Given this list of marker genes Dcaf7, Syt4, Itgb3, Dapp1, Klf12, Erbin, Rhbdl3, Arhgap32, Gas7, Tyk2, Camta1, Igf2r, Acp2, Map2k4, H2-D1, Spcs3, Elovl1, Mex3c, Ctns, Crygs, Cdk18, Tpm3, Bsn, Slc45a4, Ralgapa2, Klhl28, Heyl, Lrrc74b, Creb3l2, Fbrs, Pkia (protein kinase inhibitor, alpha), Strada, Pag1, Acad8, Cacna1d, Tanc2, Nckap1l, Shc1, Sox6, Gnao1, Osbp2, Selenov, Plekhm1, Vezt, Zcchc24, Mapk10, Zmat1, Tmem250, Egln3, Snx6, Wwp2, Pik3cg (phosphatidylinositol-4,5-bisphosphate 3-kinase catalytic subunit gamma), Nhlrc2, Otud7b, Ptpn3, Kdm3b, Abhd3, Phf21a, Caln1, Npr1, here is a description of the gene set: from publication Chen Y, Wang X (PMID 31504780) Mouse Gene Set: MIR_6991_3P Genes predicted to be targets of miRBase v22 microRNA mmu_miR_6991_3p in miRDB v6.0 with MirTarget v4 prediction scores > 80 (high confidence targets). studied in species Mus musculus